Given this list of marker genes ZNF426, ATF2, CHAD, ARMCX6, SLC6A1, ATP2B2, CCDC150, SLC24A3, TRIM67, HIC2, ITGBL1, ZNF503, MAPK6, ZNF148, MGAT5B, RTKN2, ITFG2, ZDHHC21, SEMA6A, IL17RD, TMEM178B, SP6, SYT15, SYN1, MTHFR, TNRC6C, KCNK17, SAP130, PAQR4, TNK2, TRIM29, SOD3, SNX27, ATCAY, BTN3A1, GRB2, SMCP, ZNF827, SMG6, ISCA1, ELMO1, CPS1, S100A4, CACNA1E, ERGIC1, H2BC21, VWDE, IRF2BP1, FRAT2 (NCBI Gene Id 93368), TMEM161B, PLEKHG4B, GSG1L, OPCML, TTYH3, ENTPD2, MS4A10, ZDHHC22, PREP, EDA (NCBI Gene Id 90878), TTC39C, SYNPO2L, APPL2, CMTR1, SMURF1, PRRT1, EBF1, CALN1 (calneuron 1), LINC02694, SHC1, SCRN3, UAP1L1 (UDP-N-acetylglucosamine pyrophosphorylase 1 like 1), here is a description of the gene set: from publication Chen Y, Wang X (PMID 31504780) Human Gene Set: MIR363_5P species: Homo sapiens Genes predicted to be targets of miRBase v22 microRNA hsa-miR-363-5p in miRDB v6.0 with MirTarget v4 prediction scores > 80 (high confidence targets).